Given this list of marker genes Trex2, Apex1, Trex1 (three prime repair exonuclease 1), Rad1, Exo1, Apex2, Rad9a, here is a description of the gene set: studied in species Mus musculus Mouse Gene Set: GOMF_DOUBLE_STRANDED_DNA_EXODEOXYRIBONUCLEASE_ACTIVITY Catalysis of the sequential cleavage of mononucleotides from a free 5' or 3' terminus of a double-stranded DNA molecule.